The following is a description of a gene set: The ability of the interphalangeal joints to move beyond their normal range of motion. Hypermobility of interphalangeal joints species: Homo sapiens Human Gene Set: HP_HYPERMOBILITY_OF_INTERPHALANGEAL_JOINTS, and this is the list of marker genes: COL1A2, COL3A1, SP7, PUF60, ECEL1